Given this list of marker genes UMOD, SLC14A1, POU3F3, AQP7, AQP8, AQP9, SLC14A2, here is a description of the gene set: studied in species Homo sapiens Human Gene Set: GOBP_UREA_TRANSMEMBRANE_TRANSPORT The process in which urea, the water-soluble compound H2N-CO-NH2, is transported from one side of a membrane to the other by means of some agent such as a transporter or pore.